Given this list of marker genes PRR12, FGF3, PAX6, FBXW11, TRIM44, FOXC1, here is a description of the gene set: studied in species Homo sapiens Lens coloboma A sectoral indentation of the crystalline lens, usually due to zonular weakness or absence. Human Gene Set: HP_LENS_COLOBOMA